Given this list of marker genes GTF2IRD2B, ZBTB26, SP4, ZNF19, ZNF576, ZBTB2, ZNF148, ZNF581, ZNF711, FOXD2, ZIM2, HOXA6 (NCBI Gene Id 3203), SRY, NR1H3, SPZ1, ZNF280D, TCF7, ZNF625, CSRNP3, BHLHE41 (NCBI Gene Id 79365), ZNF219, ZNF454, TAL1, NHLH1, ZNF772, ZBED4, TPRX1, ZNF134, ZNF446, ZFP30 (ZFP30 zinc finger protein), E4F1, KLF5, NEUROG3, ZNF540, DUXB, ZNF583, TLX2, EGR4, ZNF232 (NCBI Gene Id 7775), RHOXF2B, GRHL3, MECOM, GBX1, LHX4, AEBP1 (AE binding protein 1), MAFA, ZNF527, SALL3, IKZF4, ZKSCAN2, ESR2, ZNF486, NEUROG1, NRF1, ZFP69B, ETV6, GLI3, THAP11, LEF1, DMTF1, ZNF146, PKNOX1, E2F8, RFXANK, ZNF644, ZNF888, ZNF20, SALL2, NR5A2, GMEB1, NPAS3, CPHXL2, TBR1, ZNF160, ZNF497, SP6, MYF5, ZNF764, ZNF449, GLIS2, ZNF169, FOXD4L3, HELT, GATA2, NR2E3, ZBTB16, ZNF610, POU5F1, PAX4, AHR, OTX2, SOX1, EVX2, ZNF587B, GSC2, HEY1, RBPJL, ZFP92, SMAD9, ZNF771, ZSCAN4, ZNF746, NFATC3, SP140, NFATC1, ZNF699, PAX3, ZNF501, SOX21 (SRY-box transcription factor 21), ZNF286A, NANOGP1, NANOGNB, NR1D2, SKOR2, ZNF354A, HOXC8, ZNF646, ZNF404, IRX6, FOXD4, HESX1 (HESX homeobox 1), TGIF1 (TGFB induced factor homeobox 1), THRA, ZNF543, MXD4, ZNF624, KLF15, ZNF75CP, MKX, ZBTB22, NFAT5, ZFX (NCBI Gene Id 7543), LBX1, NKX2-8 (NCBI Gene Id 26257), DBX2, KLF2, USF3, ZNF724, NR1I2, ZNF441, JUND, ZNF492, TCF7L1, ZNF861P, ZHX2, ZNF684, ZNF736, VDR, ZKSCAN4, NR2F2, NKX2-1, ETV2, HOXD10, ZNF155, ZNF181, ZNF500, DMRTC2, DDN, NACC1 (NCBI Gene Id 112939), ZNF573, ZNF461, CREB3, SP140L, VAX1, NPAS1, ZNF75D, ZSCAN9, ZNF530, NKX2-4, GLI4, ZNF695, ZIC4, ZNF837, SMAD4, ESR1, ZNF705D, HOMEZ, AR, EGR3, ZNF177, DLX6, ZNF654, PRDM15, SOX15, ZNF184, ZNF696, ZNF559, ZNF599, NR6A1, HSF4, ZNF704, HOXB6, KLF1, ZNF431, ZNF534, ZBTB20, TBX18, HOXB8, MYB (MYB proto-oncogene, transcription factor), EMX2, FOXG1, ZNF818P, ZNF705B, LITAF, ZKSCAN3, ZC3H8, ZKSCAN8, ZNF234, ZNF135, ESX1, VENTX, SREBF2, TGIF2, HLF, LMX1B, ZNF805, ZNF419, ZNF687, CEBPE, SOX18, POU2F3, HOXA4, HAND1, ZNF878, UNCX, MEF2B, ALX1, SIX4, RXRA, ZNF28, ZNF394, MYPOP (NCBI Gene Id 339344), ZFP14, ZNF415, BMAL2, MSX2, ZNF211, CDX1, ZEB1, KLF7 (NCBI Gene Id 8609), HOXA11, TBX19 (NCBI Gene Id 9095), ZNF740, TSHZ1, YY2, ISX, ZSCAN20, E2F7, PEG3, HOXC13, KLF10, HEY2, CUX2, ZNF324, MZF1, KLF4, SIX6, KLF6, ZBTB42, AFF3, ZNF275, MAFG, ZNF563, FOXO1, ZNF101, ZNF121, ANHX, PRDM11, ZBED2 (NCBI Gene Id 79413), ZNF639, ALX4, ATF3, PASD1, SOX14, KLF17, ZNF662, FOXJ2, HOXA2, HOXA7, IRF2, ZNF595, ZBTB47, ZNF713, IKZF5, MAX, HOXA1, NKX2-2, IRF1, TPRXL, NFX1, ZNF683, HOXC4, GABPA, ADNP2, ZNF718, ZNF202, ZNF287, ZNF77, ZFHX4, ZNF675, ZNF487, ETV5, NFE2L3, MGA, ZNF555, HOXC10, ZNF143, ZFP82, ONECUT2, RELA, ZNF518B, KLF18, PAX6, ZNF655, BCL11B (BCL11 transcription factor B), ZSCAN5B, ZNF154, ZBTB17, SHOX2, PGRMC2, ZNF256, FOXR2, ZNF710, NPAS4, FOS, ZNF331, ZNF195, HNF4G, SCAND2P, ZBTB6, CC2D1A (NCBI Gene Id 54862), ZNF174, TFEB, ZNF426, TBX10, TLX3, ZSCAN32, CSRNP1 (NCBI Gene Id 64651), CREBRF (NCBI Gene Id 153222), SPDEF, ZNF284, IKZF3, NKX3-2, ZFP57 (NCBI Gene Id 642028), FOSL2, KLF9, DMRTB1, SAMD11, PBX4, ZNF397, ZNF391, ZNF367, TEAD2, TSHZ2, POU2F1, ZNF669, MLXIPL, TFAP2B, MAF, GATA5, USF1, PPARA, ZBTB33, FOXO4 (forkhead box O4), BSX, ZNF383, ZNF750, SCX, SKOR1, ZNF763, ZIC3, NFIX, ZNF451, FERD3L, ZNF816, MXI1, NOTCH4, NFIA, ZNF235, ZNF799, ZNF566, ZNF205, ASCL3, ELK4, FOXA1, SOHLH1, ZSCAN25, ZNF18, ZNF273, ZSCAN5DP, ZNF24, ISL2, TFDP1, ZBED1, SEBOX, STAT6, HSFX4, OSR1, ZNF37A, KLF3, ZBTB14, ZNF551, CREB3L3, BATF3, ATF6, POU6F1, ZNF213, NFE2L2, TFEC, HOXB13, ZNF491, ZNF502, LEUTX, BCL6, TCF12, ZNF223, MNT, ZNF730, ZFP90, ZNF470, SP3, ZNF561, GLI2, ZNF280A, ZFY, ZNF682, ZNF768, ZNF354B, FOXD4L1, TGIF2LX, NACC2, EBF1, CC2D1B, ESRRG, PDX1, PAX2, EBF4 (EBF family member 4), JUNB, ZNF230, CRX, ZNF700, SMAD2, RUNX3, HOXD1, ZNF691, ZNF660 (zinc finger protein 660), ZBTB11, RAX2, CARF, NOTO, IRF6, HOXA9, ZBTB48, FOXD4L4, RHOXF1, ZNF408, FEZF1, NOTCH1, ZBTB7C, ZNF784, EBF2, ZNF212, ZNF358, ZNF34, ZNF140, TEAD1, EGR2, RFX8, ONECUT1, CSRNP2, HOXD12, TRPS1, ELF5, ESRRB, ZNF627, NANOG, ZNF609, DBP, TBXT, ZNF596, MAFK, ZNF557, ZNF701, ZNF66, DACH1, HNF1A (NCBI Gene Id 6927), PROP1, SIX5, ZNF506, ZBTB45, GTF2I, GCM1, ASCL1, REL, ZNF592, PROX1, ZNF398, ZBTB18, GPBP1, SCRT1, TWIST1, LHX9, HOXC6, ZFP69, ZNF281, ZNF774, ZNF343, TBX20, VAX2, STAT5B, ZNF619, ARX (NCBI Gene Id 619216), NKX6-2, FOXC2, LYL1, TP63, FOXR1, SOX2, HOXD11, ZNF69, LHX8, SAMD7, FOXO6, GBX2, ZNF775 (zinc finger protein 775), ZKSCAN5, TFCP2, ZNF777, TAL2 (NCBI Gene Id 6887), ZIK1, FOXL1, SPIC, ZFP42, FOXP3, NFE2L1, RUNX2, ZNF45, STAT3, ZNF793, ZNF16, PLAG1, HIC2, POU5F1B, ZNF90, ZNF554, AHDC1, ZNF705G, ZNF8, NFE2, ZNF23, VEZF1, SATB1, HOXC5, ZNF92, ZNF670, TP73, ZNF85, CPHXL, HOXB4, ZNF821, ZNF410, INSM2, MEF2D, MNX1, CASZ1, ZNF865, ZNF826P, FOXD4L5, ZNF480, IRF8, HNF1B, HOXD13, MYOG, SIX1, ZNF483 (zinc finger protein 483), LHX3, NKX1-1, KLF16, ZNF433, HNF4A, ZEB2, CEBPB, MEIS1, ZNF175, ZNF529, FOXP2, ZNF304, OLIG1, FOXB1, ZNF580, IRF4, ARNT2, SOX7, ZNF584, TSHZ3, HDX, NKX2-3, ZNF528, ZNF347, DEAF1, E2F1, ZNF616, ZNF569, FOSL1, IRX2, HHEX, NR2F6 (nuclear receptor subfamily 2 group F member 6), ZNF283, KLF13, NR2C1, ZNF131, ZNF665, ZNF780B, BARHL2, NR4A2, PURB, NR3C2, FOXI1, ZNF578, FOXJ1, TCFL5, DDIT3, ATF7, PGR, MYF6, RELB, THRB, EN1, ZNF345, HMX1, POU3F2, PRDM2, E2F4 (E2F transcription factor 4), FOXK2, TFAP2E, MYT1L, YY1, MYRF, ZNF512, ELK3, ZNF702P, MYCN, TFCP2L1, ISL1, ZNF716, MITF, ZBTB38, ZNF648, SKI, MEF2C, EOMES, ZNF614, MLXIP, ZNF572, ZSCAN5A, E2F3, POU1F1, SPI1, HEYL, PRDM1, ZNF677, ZNF556, ZNF317, POU4F3, HOXD8, ZNF253, ZNF30, BORCS8-MEF2B, ZNF577, ZNF620, MXD1, DUX4, EGR1, JPH2, SNAI2, TCF7L2, ATF4, LRRFIP1, GATA3, ZNF546, RREB1, CREBL2, ZNF773, ZNF785, TCF3, HSFY1, ZNF7, SP1, ZBTB9, NFATC2, ZNF17, ZNF214 (NCBI Gene Id 7761), GLIS3, HSF2, ELF1, SIM1, ZSCAN12, TBX22, STAT2, ZNF780A, ATF2, RFX7, PURG, TCF21, ZNF420, ZNF76, ZNF567, ZNF607, ZNF630, ZNF792, TBX3, GTF2IRD2, ZNF844, FOXN2, TEAD4, RAX, XBP1, PITX2, IKZF2, FOXD1, ZNF737, MYOD1, NR1H2, ZNF582, ZBTB24, ZNF586, AHRR, PAX9, BCL11A, SALL4, EPAS1, ZFHX2, DLX1, RFX5, RORA, FOXK1, ZSCAN21, TFAP2D, MAZ, BHLHA15, ZNF722, ZNF549, RXRG, ATF5, HIC1, SIX2, FOXL2, ZNF623 (NCBI Gene Id 9831), ZNF70, SHOX, LMX1A, CEBPG, ZNF649, ZNF292 (NCBI Gene Id 23036), ZNF22, ZNF215, ZNF337, DMRTA1, ZNF735, SIM2, FOXP1, ZNF264, KLF14, SMAD5, FOXA3, LHX5 (NCBI Gene Id 64211), ZNF562, HES4, ZNF280C, ZNF490, NKRF, GATA4, ZNF565, SCRT2, OVOL3, PITX3, ZNF697, SLC2A4RG, NFATC4, RFX1, ZSCAN30, ZNF233, TCF23, EBF3, WIZ, HMX2 (H6 family homeobox 2), NR4A1, PRDM10, ZNF879, DMRTA2, ZNF678, ZNF114, ZNF668, ZNF100, MXD3, HOXB3, ZNF524, FLI1, IRF9, ZKSCAN7, FOXC1, CTCF, FEV, ERF, IRX4, PRDM16, ZSCAN16, NKX6-3, MYBL1, ZNF334, GMEB2, NFKB2, NR4A3, ZNF575, ZBTB7A, HOXD9, POU4F2, BARX1, ETS2, MTF1, JDP2, POU3F4, ZFP28, NR5A1 (NCBI Gene Id 2516), THAP1, HOXC9, STOX1, OR51E2, ZSCAN23, MEIS3, NTN3, NTN1, ZNF705EP, ZNF766, ZNF552, NR1H4, ZNF355P, ZNF846, BBX, RFX2, EN2, NR1D1, ZNF547, NKX2-5, LHX6, FOXM1, RARG, RBAK, ETV1, EMX1, GSX2, RFXAP, TBX15, ZNF324B, ETV3, ZNF519 (zinc finger protein 519), ZBTB39, ZBED3, FOXN3, SOX4, BHLHE22, FOXD4L6, GPER1, ZNF676, SMAD1, ZGPAT, BACH2 (BTB domain and CNC homolog 2), ZNF266, SOX5, ZNF320, ZNF3, OTX1, MEF2A, ZNF439, ZNF823, ZNF251, RUNX1, SP110, DLX3, IRX3, MEOX1, HOXD4, FOXI3, ZNF80, NFIL3, ZNF221, OVOL2, PAX8, NKX2-6, CREB3L1, ZNF652, ENO1, MYNN, SNAI3, ZNF723 (zinc finger protein 723), ZNF35, ETV7, DBX1, MYC, ZNF883, SKIDA1, SOX11, ZNF416, ZNF418, ARID3C, ZIC5, ZNF443 (zinc finger protein 443), TFDP2, FOXH1, ZNF568, ZNF705A, ZNF833P, PPARD, ZNF71, PBX2, ZNF571, ZNF296 (NCBI Gene Id 89860), HSF1, TBX5, ZNF679, NEUROD2, ADNP, ETV3L, ZNF560, ZNF460, HDAC5, HLX, ASCL2, ZBTB8A, FOXE3, PITX1, HOXB1, ELF4, RFX3, BATF (NCBI Gene Id 10538), DUXA, HES1, ZNF860, ZFP3, GZF1, ZBTB12, HOXD3, TEF, NFIB, ZNF25 (NCBI Gene Id 7573), SOX3, HAND2, FOXF2, CREB3L4, HOXA10, DLX4, ZNF81, LHX1, POU3F1, NRL, EVX1, ST18, ZSCAN5C, ZBTB5, KCNIP3, FOXJ3, ZSCAN10, ZNF180, PCBP1, DRGX, ATF6B, ZNF417, CDC5L, ZBED6, HES2, PLSCR1, SOX12, DPRX (NCBI Gene Id 503834), ZNF728, DMRTC1B, HOXB5, ZNF280B, ZNF511, MESP2, NKX3-1, DMRT2, FOXS1, NR2E1, TFDP3, ZBTB3 (zinc finger and BTB domain containing 3), ATOH8, ZBTB49, ERFL, PAX7, NPAS2, ABHD2, ZNF189, ZNF10, ZNF74, SP9, ZSCAN31, NKX1-2, FOXB2, DMBX1, PURA, ZFHX3, ZNF835, TP53, ZNF165, BHLHE23 (NCBI Gene Id 128408), ZNF518A, E2F2, ZNF141, NOBOX, ZNF350, ZNF239, TEAD3, TPRX2, RLF, PPARG, ZNF341, PRDM4, RORC, HDAC4, ZNF468, IRF7, PDE3A, SIX3, ZNF589 (NCBI Gene Id 51385), ZNF254, ZFP37, ZNF550, ZNF362, ZNF689, ETV4 (ETS variant transcription factor 4), MIXL1, HIF1A, GRHL2, ZNF222, ZNF688, SPIB, ZFP1, MYRFL, CREB1, SOX6, ZNF438, ZNF133, ZIM3, SMAD3, ZNF138, ZNF621, MYCL, ZBTB40, ZNF892, ZSCAN2, ZNF783, ZNF672, ZNF579, ONECUT3, SOX9, ZNF852, ZFAT, ZNF496, SALL1, NEUROD6, GLI1, ZNF423, ZNF611, ZNF248, ZNF286B (zinc finger protein 286B (pseudogene)), ZNF749, SNAI1, GATA6, DMRT1, ZNF250, ZNF83, TLX1, ZNF182, ZNF791, ZNF263, STAT4, BARHL1, ZNF790, HINFP, SOHLH2, ZFP41, BCL6B, DMRT3, EHF, ZBTB37, POU5F2, NKX6-1, MEOX2, ZNF628, ZIC1, ZNF132, ZNF587, TBX2, E2F6, TWIST2, ZBTB41, ELF2, CEBPD, ZNF91, PAX5, JUN, ZNF430, SREBF1, ZNF559-ZNF177 (ZNF559-ZNF177 readthrough), ASCL4, ZNF124, ZNF142, MYT1, FOXN4, WT1, PHOX2B, HES3, HOXC12, ATOH1, ZNF316, ZNF32 (NCBI Gene Id 7580), TBX1, HOXA3, NFXL1, KLF12, HSF5, FOXE1, IRX5, VSX2, NFYA, ZNF442, SP100, NEUROD4, NHLH2, CIC, ZNF75A, RXRB, MEIS3P1, HBP1, ZNF891, ZBTB32, ZNF224, MEIS2, CREBZF, POU4F1, ERG, NFKB1, SP7, ZNF787, ZNF136, ZNF800, RARB, ZNF396, ZNF33A, FOXF1, ZNF117, OTP, HOXB2, HOXC11, ZBTB7B, ZNF570, HIVEP2, ZNF444, ZNF876P, ZNF707, STAT1, SOX10, ZNF260 (NCBI Gene Id 339324), POU6F2, KLF8, BACH1, MAFB, ZNF613, RFX4, PHOX2A, ELF3, ZNF880, ZNF436 (zinc finger protein 436), BATF2, ZNF274, ZNF813, GFI1B, ZNF674 (zinc finger protein 674), ZNF512B (zinc finger protein 512B), SOX13, ETS1 (ETS proto-oncogene 1, transcription factor), ZNF853, ZNF776, NR2C2, INSM1, ZNF714, ZNF681, ZNF236, ZNF727 (zinc finger protein 727), LHX2, ZBTB43, ZNF382, NEUROG2, HES5, SATB2, SRF, ZNF516, HDGF, FEZF2, HES6, HIF3A, TBX4, ZNF98, IRF5, PTF1A, SKIL, CREM, BHLHA9, ZNF322, ZNF875, ZBTB10, ZNF781, ELK1, ASCL5, ZNF829, ZNF257, ZHX3, TFE3, SOX8, NEUROD1, ZNF282, NR2F1, CUX1, NFYB, VSX1, ZNF440, ZNF300, RFX6, ZNF548, ZNF765, IRX1, ZSCAN18, ZNF664, ZHX1 (zinc fingers and homeoboxes 1), GSC, PAX1, ZNF532, ZNF709, GFI1, ZNF12, ZNF354C, NFIC, SP5, BMAL1, ZNF217, ZBTB8B, HSFX3, HOXA13, ZNF558, RBPJ, NR3C1, HMX3 (NCBI Gene Id 340784), TFAP4, ZNF789, CREB5, LBX2, ATF1, HSFX2, FOXP4, CEBPA, ZNF471, MSC, E2F5, PAQR8, ZNF542P, USF2, CDX2, FOXO3, ZNF44, OVOL1, FOXN1, ZNF761, NR1I3, DMRTC1, ZNF778, REST, RARA, SP8, STAT5A, ZNF667, ZNF564, NOTCH2, HOXB7, NANOGP8, ZNF93, ZNF680, ZKSCAN1, ZNF479, ATMIN, SP2, ZSCAN29, DLX5, BARX2, ZNF268, FOXA2, ZNF517, ARNT, TFAP2C, ZSCAN1 (NCBI Gene Id 284312), PRRX2, ZNF467, ZNF641, ZNF425, FOXQ1, RHOXF2, ZNF485 (NCBI Gene Id 220992), HIVEP1, TCF4, FIGLA, NFYC, HES7, CLOCK, ARGFX, GSX1, CREB3L2, DACH2, GRHL1, ZNF329, MLX, ZBTB25, PLAGL1, ZNF57, PLAGL2, IRF3, SOX17, HOXA5, TCF15, ZFP2, POU2F2, FOXO3B, ZNF79, ZBTB4, TBX6, PBX1, HOXB9, ZIC2, IKZF1, ZNF414, FOSB, ZGLP1, MYBL2, OLIG2, GLIS1, ZNF510, TGIF2LY, CDX4, GTF2IRD1, HIVEP3, ESRRA, ATOH7, PGBD1, ZNF14, CTCFL, HSFY2, OLIG3, DLX2, SOX30, BHLHE40, TCF24, PRRX1, MSGN1, ZBTB21, ZBTB46, ZNF626, ZNF732, TBX21, ZNF311, ZNF514, GCM2, ZNF285, ZNF302, ZNF395, ZNF333, ZNF671, MAFF, ZSCAN26, TFAP2A, KLF11, ZNF429, PRDM5, STOX2, PROX2, ZBTB1, GATA1, ZNF469, ZNF597, PATZ1, FOXI2, MSX1, ALX3, ZNF536, HSFX1, ZNF692, ZSCAN22, FOXD3, PBX3, ZBTB34 (zinc finger and BTB domain containing 34), PAQR7, ZNF366, MESP1, RORB, OSR2, POU3F3, UBP1, BNC1, NFILZ (NCBI Gene Id 107983991), here is a description of the gene set: A transcription regulator activity that modulates transcription of gene sets via selective and non-covalent binding to a specific double-stranded genomic DNA sequence (sometimes referred to as a motif) within a cis-regulatory region. Regulatory regions include promoters (proximal and distal) and enhancers. Genes are transcriptional units, and include bacterial operons. species: Homo sapiens Human Gene Set: GOMF_DNA_BINDING_TRANSCRIPTION_FACTOR_ACTIVITY